The following is a description of a gene set: from publication Nakaya HI, Clutterbuck E, Kazmin D, Wang L, Cortese M, Bosinger SE, Patel NB, Zak DE, Aderem A, Dong T, Del Giudice G, Rappuoli R, Cerundolo V, Pollard AJ, Pulendran B, Siegrist CA (PMID 26755593) species: Homo sapiens The dynamics and molecular mechanisms underlying vaccine immunity in early childhood remain poorly understood. Here we applied systems approaches to investigate the innate and adaptive responses to trivalent inactivated influenza vaccine (TIV) and MF59-adjuvanted TIV (ATIV) in 90 14- to 24-mo-old healthy children. MF59 enhanced the magnitude and kinetics of serum antibody titers following vaccination, and induced a greater frequency of vaccine specific, multicytokine-producing CD4(+) T cells. Compared with transcriptional responses to TIV vaccination previously reported in adults, responses to TIV in infants were markedly attenuated, limited to genes regulating antiviral and antigen presentation pathways, and observed only in a subset of vaccinees. In contrast, transcriptional responses to ATIV boost were more homogenous and robust. Interestingly, a day 1 gene signature characteristic of the innate response (antiviral IFN genes, dendritic cell, and monocyte responses) correlated with hemagglutination at day 28. These findings demonstrate that MF59 enhances the magnitude, kinetics, and consistency of the innate and adaptive response to vaccination with the seasonal influenza vaccine during early childhood, and identify potential molecular correlates of antibody responses. Human Gene Set: NAKAYA_PBMC_FLUAD_MALE_AGE_14_27YO_1D_POSTBOOST_VS_0D_PREIMM_MF59_ADJUVANTED_1DY_GENES_IN_BTM_M40_AND_M53_DN Genes down-regulated in peripheral blood mononuclear cell 1d postboost vs 0d pre-imm in children (14-27m) (MF59-adjuvanted) after exposure to Fluad, time point 1D. Comment: (B) Genes in BTM M7.0; (D) Genes in BTM M53, and this is the list of marker genes: GATA3, XCL2, MAL, GZMB, CD3E, PRKCH (protein kinase C eta), UBASH3A, PAK1, GPR171, CD6 (NCBI Gene Id 923), NELL2, CD27, TRAJ17, GZMM, EOMES, CD3G, RASGRP1, CD28, IL7R, SIT1, ZAP70, TIGIT, ICOS, CCL5, PRKCQ, SAMD3, GZMK, ITM2A, IL32, TRAT1, GIMAP7, CD96, NLRC3, LAT, TRAC, GZMH, GNLY, RORA, SIRPG, LCK, LEF1, ITK, KLRB1, BIRC3, GIMAP6, CD3D, GZMA, HLA-DQB1, TRBC1, BCL11B, NKG7, CD2, TRAV20, CD247, ETS1, SH2D1A (NCBI Gene Id 4068)